Given this list of marker genes ME3, ATP6V0D2, GALT, TMX4 (thioredoxin related transmembrane protein 4), PECAM1, NOTCH2, IARS2 (NCBI Gene Id 55699), CBX7, RNLS, DPP7, CD9, NFATC1, GALNT11, KLF7, H2AZ2, CELSR1, SLC12A6, GNAS, MBOAT1 (NCBI Gene Id 154141), SH3TC1, SNX2, AMDHD1, AP3S1, CLN6, KLF2, COMMD10, TMEM225, MRPS26, PI4KA, TIMP2, RAP2B, FRMD4A, TPCN1, RNF113A (NCBI Gene Id 7737), MBNL3, CHST13, CD302 (NCBI Gene Id 9936), OMA1, ATM, AHCYL2, ZZZ3, KCNJ5-AS1, HPCAL1, FAM13A, SKAP2, PYCARD, RWDD4 (NCBI Gene Id 201965), NUDT1, POGK, CLCN5, TRIM52, ZNF253, HHEX, NACC2, SLC39A10, TMEM33, NUPR1, GRN, RAB4A, SLC40A1, SKIC8, RNF141, WASHC5, PDXDC1, RHOB, ZNF496, ATP6V0A1, ACAD9, ASRGL1, IFI30, GMFG, DYRK4, SNX24, UCHL3, HMG20A, CA11, TMEM59, DOK2, HDLBP, ESYT1, SLC35A1, HEXA, ERCC5, SLC2A9, EPB41L2, RAB42, PCYOX1 (NCBI Gene Id 63081), UBR5, MRPS34, CCDC92, CLN3, HADHB, PTPN18, PHYH, BLCAP, SULT1A1, CBX1, CAD, COMT, ALDH3B1, CCDC88A, COMMD6, NFATC3, RITA1, KCTD12, TMEM37, CCSAP, TMEM147, VAMP8, TIMMDC1, SLC35F6, TCF3 (transcription factor 3), SEC14L1, EPAS1, NPL, RDH12, TNFRSF21, RIN3, DDHD1, IFT20, CDK19, GDE1, ZBTB4, CELF6, VMA21, NLRC4, DDIAS, UBXN11, TGFBR2, PFDN5 (NCBI Gene Id 5204), EEF1G, FCGRT, SH3PXD2A, ECHDC1, SPATA12, B3GNT2 (UDP-GlcNAc:betaGal beta-1,3-N-acetylglucosaminyltransferase 2), PLXDC2, SCCPDH, DUSP23, NTAN1, ZNF703, RABL6, TPP1, DNASE2B, TXNRD3, GAA, SLC30A9, SLC29A1, TPD52L2, ATP6V0D1, STX10, MPG, PLCB2, LRRC58, DOP1B, ZCCHC24, NCKAP1L, CUTA, PEPD (peptidase D), C7orf50, DCBLD1, PIGK, ZNF589, EVA1B, DDX46, DIP2C, LMAN2, MYCBP2, RUSF1, LCLAT1, HACD3, BMP2K, SYK, SETD7, NDUFB9 (NCBI Gene Id 4715), RPN1, EIF4EBP1, UQCRC1, SLC48A1, HSD3B7, FAM185A, MRTFB, LYL1, FBXO7, ZNF274, BLVRB, TLR4, ZBTB33, ANP32A, MXI1, QSER1, ARHGDIB, CRTAP, VPS36, STK40, GLUD1, NFXL1, RREB1, TMEM245, here is a description of the gene set: Human Gene Set: GSE9960_HEALTHY_VS_GRAM_NEG_SEPSIS_PBMC_UP studied in species Homo sapiens from publication Payen D, Lukaszewicz AC (PMID 19535937) Genes up-regulated in peripheral blood monocytes (PMBC): healthy versus Gram negative sepsis. To identify signature genes that help distinguish (1) sepsis from non-infectious causes of systemic inflammatory response syndrome, (2) between Gram-positive and Gram-negative sepsis.